The following is a description of a gene set: species: Homo sapiens Human Gene Set: GOBP_POSITIVE_REGULATION_OF_LIPOPROTEIN_PARTICLE_CLEARANCE Any process that increases the rate, frequency, or extent of lipoprotein particle clearance. Lipoprotein particle clearance is the process in which a lipoprotein particle is removed from the blood via receptor-mediated endocytosis and its constituent parts degraded., and this is the list of marker genes: MIR379, MIR144, TREM2, ANXA2, HNRNPK, GPLD1, LDLRAP1, GPIHBP1, MIR302A, LIPG, MIR33B, MIR33A